The following is a description of a gene set: Human Gene Set: HP_RENAL_CYST species: Homo sapiens A fluid filled sac in the kidney. Renal cyst, and this is the list of marker genes: BBS10, PEX14, LRP5, GLIS3, KAT6B, PORCN, PMM2, SCLT1, TMEM218, TMEM138, RERE, FIBP, IFT140, ARL6IP6, SPEN, NIPBL, NEK8, ETFB, COMT, PIK3CA (phosphatidylinositol-4,5-bisphosphate 3-kinase catalytic subunit alpha), IFT80, AMER1, UMOD, DLG5, GPC4, LAMB3, PKD1 (polycystin 1, transient receptor potential channel interacting), SEC24C, GTF2I, TRIM32, NEUROD1, TMEM231, PEX10, B4GAT1, IGF2, PEX12, HNF4A, PEX1, ALG9, MYT1L, PDX1, PBX1, MKKS, DCDC2, SCAF4, KCNQ1OT1, IFT172, NPHP3, CSPP1, BUB3, IFNG, BBS12, TCTN3, MT-CYB, TMEM107, VHL, PEX11B, RMND1, CEP120, METTL27, CFAP418, TMEM270, FLI1, CLIP2, BMPER, MUC1, IFT43, EHMT1, JAM3, TMEM216 (transmembrane protein 216), ARL6, CASZ1, BBIP1, AP2S1, LUZP1, ETFDH, ABCC8, EXTL3, RAD21, NXN, B9D1, DZIP1L, MCTP2, PEX2, BBS1, TRRAP (transformation/transcription domain associated protein), ESCO2, BICC1, PIGQ, HSPG2, LIMK1, CEP57, SEC63, GTF2IRD1, AKT1, CEL, ZMYM3, SEC61A1 (SEC61 translocon subunit alpha 1), BUB1B, KDM6A, DNAJC30, SIX5, GTF2IRD2, TRIP13, PRKCZ, PIEZO2, GANAB, TSC1, PEX13, TXNDC15 (thioredoxin domain containing 15, NCBI Gene Id 79770), NAA10, TBL2, ACTG2, PEX5, ROR2, TCTN1, FAN1, TRIP11, GNA11, TMEM260, PEX16, EYA1, HIRA, BBS5, CEP55, JAG1, NCF1, JMJD1C, SIX1 (NCBI Gene Id 6495), ZNF148, ETFA, CLPB, PAX2, PEX19, TMEM67, PKHD1, KIAA0586, LMOD1, TTC8, FLCN (folliculin), HOXD13, GPC3, AKR1D1, SCAPER, FLNB, WDR35, OFD1 (NCBI Gene Id 8481), ELN, HDAC4, PAX1, ARVCF, MYLK, SKIC2, BBS4, RAD51C, CRB2, XPNPEP3, UBE4B, VPS37D, KMT2D, PEX6, OCRL (NCBI Gene Id 4952), RPGRIP1L, TCTN2, MAPKBP1, TKT, UFD1, TBX1, BUB1, KCNJ11, INS, SMC3, SALL1, BBS9, TFAP2A, ALG5, DHCR7, ARL3, TMEM237, GABRD, BRD4, BUD23, BLK, CWC27, NRIP1, CEP290, GREB1L, STK11, SPOP, SETBP1, MMP23B, MBTPS2, LIG1, IFT74, LAMA3, CHRM3, DYRK1A, PKD2, RFC2, PEX3, ALG8, GP1BB, GCK, DACT1, LAMC2, STX1A, PAX4, KLF11, BBS7, MKS1, MPI, CPT2, RNU4ATAC, LZTFL1, COL4A1, SDCCAG8, DYNC2I2, DYNC2H1, GLI3, KCNAB2, B3GLCT, NOTCH2, FKBP6, SKI, TSC2 (TSC complex subunit 2), ANKS6, SKIC3, RSPO2, PDPN, GATA3, PIGT, ZEB2, HNF1B, NPHP1, MSH3, TAF6, WNT3, DHX16, INPP5E, HDAC8, DNAJB11, HSD17B4, SMC1A, PRDM16, WDPCP, BAZ1B, NEK1, HNF1A (NCBI Gene Id 6927), B9D2, EIF4H, IFT27, MPDU1, PRKCSH, PEX26, APPL1, RPGRIP1, CEP19, CDKN1C, TBC1D24, CCND1 (cyclin D1), SHANK3, DYNC2I1, MYH11, INVS (inversin), LHX1, KCNQ1, SRCAP, CD96, NPHP4 (nephrocystin 4), PUF60, NCAPG2, RREB1, SNRPB, CC2D2A, SF3B2, CDC73, TULP3, TBX4 (NCBI Gene Id 9496), SH2B1, BBS2, ZNF423, PIGN, MAB21L1 (mab-21 like 1)